The following is a description of a gene set: Mouse Gene Set: JECHLINGER_EPITHELIAL_TO_MESENCHYMAL_TRANSITION_UP Epithelial-to-mesenchymal transition (EMT), a switch of polarized epithelial cells to a migratory, fibroblastoid phenotype, is increasingly considered as an important event during malignant tumor progression and metastasis. To identify molecular players involved in EMT and metastasis, we performed expression profiling of a set of combined in vitro/in vivo cellular models, based on clonal, fully polarized mammary epithelial cells. Seven closely related cell pairs were used, which were modified by defined oncogenes and/or external factors and showed specific aspects of epithelial plasticity relevant to cell migration, local invasion and metastasis. Since mRNA levels do not necessarily reflect protein levels in cells, we used an improved expression profiling method based on polysome-bound RNA, suitable to analyse global gene expression on Affymetrix chips. A substantial fraction of all regulated genes was found to be exclusively controlled at the translational level. Furthermore, profiling of the above multiple cell pairs allowed one to identify small numbers of genes by cluster analysis, specifically correlating gene expression with EMT, metastasis, scattering and/or oncogene function. A small set of genes specifically regulated during EMT was identified, including key regulators and signaling pathways involved in cell proliferation, epithelial polarity, survival and trans-differentiation to mesenchymal-like cells with invasive behavior. from publication Jechlinger M, Grunert S, Tamir IH, Janda E, Lüdemann S, Waerner T, Seither P, Weith A, Beug H, Kraut N (PMID 14562044) species: Mus musculus Genes up-regulated during epithelial to mesenchymal transition (EMT) induced by TGFB1 in the EpH4 cells (mammary epithelium cell line transformed by HRAS)., and this is the list of marker genes: Ifitm3, Tnxb, Pcolce, Sdc2, Cdh2, Rras, Ppic, Bcl3, S100a8, Ifit1, Pdgfra, Pla2g7, Srm, Slc3a2, Col3a1, Pmp22, Ptpn22, Cxcl5, Sdc1, C4b, Galk1, Stat1, Procr, Cdh15, Mmp2, Adss1, B2m, Gas1, Csn3, Lamb1, Mmp13, Ifit3, Isg15, Sparc, Il11, Vim, Col6a2, Cfh (complement component factor h), Cd68, Ada, Fmo1, Rnaset2b, Irf7, Htra1, Asns, Ctsz, Cxcl1, Ackr3, Cck, Gbp3, Phgdh, Col6a1, Hif1a, Prl2c3, Ddr2, Ptgs1, Upp1, Dcn, Cyp1b1, Vldlr, Mmp12, Tnc, Inhba, Dab2, Snai1, Slpi, Serpinh1, Ccl2, Pdgfrb, Mthfd2